The following is a description of a gene set: species: Homo sapiens Neighborhood of RAB5A Neighborhood of RAB5A RAB5A, member RAS oncogene family in the MORF expression compendium Human Gene Set: MORF_RAB5A, and this is the list of marker genes: RPP38, PPP1R7, IST1, SLC25A1 (solute carrier family 25 member 1), RAB1A, MAPK3, EIF2B2, ENSA, FUBP1, TMED2, PPP6C, MBD4, TM9SF1, TMED10, PSMC1, ATP6V1H, COX7A2L, YWHAB, COX4I1, GRINA (NCBI Gene Id 2907), RNF6, VPS72, DDB2, UBE4A, PEX11B, MAD2L1BP, SRP19, COPB2, TAPBP, RPL36AL, ELOB, PICALM, SYPL1 (NCBI Gene Id 6856), OGFR, VTI1B, ARF5, WBP2, RAB5A, PSMC2 (NCBI Gene Id 5701), HARS2, COX5A, UBR5, GMFB, PDCD6, SMG7, NBN, CLN3, GPR107, TPM4, BUD31, RAE1, EFR3A, SDHC, MORF4L2, DUSP11 (NCBI Gene Id 8446), ADAR, EIF5, RAD23B, DPM1, DNPEP, SKP1, HSBP1, ATP6AP2, STX16, TMBIM6, ZNF410, PSMB4, RER1, CLEC18C, PSMC6, ARF3, BCAP31, COIL, CFDP1, PSMA3, ATP5MF, CHMP2B, RNF114, ISCU, ATP6V1E1, CNIH1, ATOX1, ATP6V0D1, NPTN, UBA1, BAG5, RAC1, RAB9A, PSMD7, UBXN4, CD47, EBAG9, MYL11, SUMO1, SEC13 (SEC13 homolog, nuclear pore and COPII coat complex component)